The following is a description of a gene set: Genes predicted to be targets of miRBase v22 microRNA mmu_miR_7042_5p in miRDB v6.0 with MirTarget v4 prediction scores > 80 (high confidence targets). studied in species Mus musculus Mouse Gene Set: MIR_7042_5P from publication Chen Y, Wang X (PMID 31504780), and this is the list of marker genes: Arl5b, Nhsl2 (NCBI Gene Id 68850), Pum1, Cpne5, Ncald, Pag1, Gm38423, Arl14ep, Tmem108, Ythdf3, Capn7, Slc6a2, Rap2c, Il1r1, Slc26a3, Sh3bgrl2, Tigit, Frmpd4, Msantd5f4, Mysm1, Gpr165, Ppp2r5e, Etnk1, Ifi204, Spn, Rftn2, Nabp1, Zbtb8b, Mmp1a, Ccdc59, Med23, Tead1, Csrnp1, Pcnx1, Sgms1, Tmem130, Sema5a, Lrrc4c, Atf7, Prrg3, Tanc2, Grem2, Gpat3, Mapk10, Vhl, Aak1, Lck, Zbtb41, Pus7l, Hs3st2, Bgn, Arhgap23, Lsamp, Cdh11, Srsf3, Tnfsf15, Gvin3, Klhl8, Snx16, Mxd1 (MAX dimerization protein 1), Triqk, Msantd5f6, Ddx3x, Dnajc21, Slc8a3 (solute carrier family 8 (sodium/calcium exchanger), member 3), Ccdc70, Mecp2, Msantd5f3 (Myb/SANT DNA binding domain containing 5 family member 3), Calr, Ptar1, Hgsnat, Chm, Vegfa, Igfbp2, Slc39a7, Large1, Efna5, Ccdc39, Spast, Jam2, Cdk5r1, Pex11b, Ifi203, Sp110, Sgpl1, Noct, Zmym3, Mup2, Dnmt3a, Ehf, Syna (syncytin a, NCBI Gene Id 547440), Nfib (NCBI Gene Id 77183), Tm2d1, Ash1l, Msantd5f1, Caln1, Arglu1, Sorcs1, Pam, Vamp1, Rnpc3, Cst5, Slc11a2, Gm16430, Csf2rb2, Lif, Ypel2, Mmp1b, Sdc2, Eya4, Hivep2, Stra6l, Slc12a8, Kcnb1, Sdccag8, Msantd5f5, Krtap6-3, Mbtps2, Msl1, Grpr, Nav2, Fzd3, Gucy1a2, Chic1, Gtf3c4, Dnm3, Zscan12, Tfcp2l1, Dnah11, Emc1 (ER membrane protein complex subunit 1), Ncl, Chit1, Epha3, Tcerg1, Cacna1b, Elfn2, Zyg11b, Rapgef6, Vcpip1, Msantd5f2, Slxl1 (Slx-like 1), Astn2, Ctf1, Pdlim5, Terb2, Gm16405, Sema4d, Ifi207, Tspan12, Set, Rgs7bp